The following is a description of a gene set: Mouse Gene Set: GOBP_NEGATIVE_REGULATION_OF_CARDIAC_MUSCLE_CELL_DIFFERENTIATION Any process that stops, prevents or reduces the frequency, rate or extent of cardiac muscle cell differentiation. studied in species Mus musculus, and this is the list of marker genes: Ccnd2, Dkk1, Smad4, Fzd7, Frs2, Dll1, Bmp2, Hdac3, Sox6